The following is a description of a gene set: Human Gene Set: HP_BLOCK_VERTEBRAE species: Homo sapiens Congenital synostosis between two or more adjacent vertebrae (partial or complete fusion of adjacent vertabral bodies). Block vertebrae, and this is the list of marker genes: ZIC3, HES7 (hes family bHLH transcription factor 7), DLL3, FLNB, SF3B2, MESP2